Given this list of marker genes Xdh, Maob, Becn1, Alad, Glud1, Lonp1, here is a description of the gene set: Mouse Gene Set: GOBP_RESPONSE_TO_ALUMINUM_ION studied in species Mus musculus Any process that results in a change in state or activity of a cell or an organism (in terms of movement, secretion, enzyme production, gene expression, etc.) as a result of an aluminum ion stimulus.